The following is a description of a gene set: studied in species Homo sapiens The appearance of transforming growth factor-beta2 due to biosynthesis or secretion following a cellular stimulus, resulting in an increase in its intracellular or extracellular levels. Human Gene Set: GOBP_TRANSFORMING_GROWTH_FACTOR_BETA2_PRODUCTION, and this is the list of marker genes: SMAD4, ATF2, SMAD3, BMPR1A, TGFB2, GATA6, WNT11, HIF1A